Given this list of marker genes NR0B1, ZSWIM7, PPP2R3C, CYB5A, CDSN, NR5A1, RPL21, PSMC3IP, BMP15, ORC6, SEMA3E, GJB6, GJB2, BNC1, MDM2, GNRHR, WDR11, GATA4, SPIDR, ITGB4, FGF17, SOX9, ZFPM2, MSH4, DUSP6, EPS8L3, SRY, MAP3K1, TP63, AR, WWOX, FOXL2 (NCBI Gene Id 668), MRPS22, WT1, LHB, SPRY4, APCDD1, CYP17A1, LSS, NUP107, POLR3H, AXL, COL17A1, SRA1, VAMP7, ESR1, CCDC141, FSHB, GNRH1, FSHR, FEZF1, KCTD1, DHX37, ANOS1, HLA-DRA, KRT74, HR, here is a description of the gene set: Abnormality of the pubic hair Abnormality of the growth of the pubic hair. Pubic hair is part of the secondary sexual hair, which normally ensues during puberty. studied in species Homo sapiens Human Gene Set: HP_ABNORMALITY_OF_THE_PUBIC_HAIR